Given this list of marker genes GALK2, TAF6, CHID1 (NCBI Gene Id 66005), CYSLTR1, LAIR1, SMYD4, PRC1 (protein regulator of cytokinesis 1), MBLAC2, NCOR2, LEPROTL1, UBLCP1, RDH12, PPAT, SDHA (NCBI Gene Id 6389), CD38, ZNRF2, ITGB1, ARHGAP1, SH3KBP1, PLXDC2, IRF2, PABIR2 (NCBI Gene Id 159090), RYK, UBQLN4, RNF13, SPI1, EIF4G1 (NCBI Gene Id 1981), MCM2 (NCBI Gene Id 94687), MPP1, NEDD4, DDB1, PRKAG2, LARS2, MLH1, IDS, PKN1, EHMT1, LRRC61, AIFM1, CD48, PPP1R21 (protein phosphatase 1 regulatory subunit 21), PIP4K2B, MLKL, SYT11, H2BC9, H2AC25, RACGAP1, MESD, GAS7, VPS45, HPS6, PTPRVP, NXPE3, XRN1, FGL2, TAOK3, TBCK, SEC24D, E2F6, CCDC69, PIP4P2, SLC35B4, ATP6V1C1, MDC1, HIRA, CYP20A1 (cytochrome P450 family 20 subfamily A member 1), UBQLN2, FAM168A, ACLY, SLC39A10, APBB1IP, SKAP2, ADD1, PPDPF, NFYB, BARD1, THOC5, DPCD, RPUSD3, OTUB1, DHX29, DHX32, FAM162B, INCENP, MPI, KNL1, INPP5B, TJP3, KIF20B, CHD9, SAMM50, SYNRG, BLVRA, COG7, CDC25B, ZBTB3, EPHA8, GNA15, SIAE, USP45, TBC1D7, SLC35A5, FAM111A, ATPAF1, PRMT7, THUMPD2, ZBTB8A, GBF1, PBK, SIKE1, DHX16, TXNDC16 (thioredoxin domain containing 16), MEN1, ACAT1, GLTP, THAP11, HP1BP3, SEPHS2, NUP133, POLR3K, MIGA1, NUMA1, CERS6, ASAH2, CPNE3, PCYOX1 (NCBI Gene Id 63081), CUTC (cutC copper transporter), TMTC4, XPNPEP1, NCOA7 (nuclear receptor coactivator 7), EME1, NUP155, MAP2K1, XPO6, GPATCH2, NUP210, IMPA1, CALHM6, CDIN1, PCYT1B, QDPR (quinoid dihydropteridine reductase), POC1B, COX19, HIP1, SDF2L1, UBTF, SPPL3, SEPHS1, HNRNPUL1, MTMR9, ACAP2, CHFR, CDC25C, ECSIT, FBXL14, CDK2AP1, CMTM6, PTCH1, OPA1, CENPF, BCS1L, TRAPPC1, GLIPR1L2, IPO9, GMFG, NXN, USP25, SPICE1, MSL1, CD79B, JAK1, SLC2A3, UROS, LRRC1, DBNL, AKR1B10, SLAIN2, here is a description of the gene set: IFNs are highly pleiotropic cytokines also endowed with marked anti-angiogenic activity. In this study, the mRNA expression profiles of endothelial cells (EC) exposed in vitro to IFN-alpha, IFN-beta, or IFN-gamma were determined. We found that in HUVEC as well as in other EC types genes were upregulated (>2-fold increase) by IFNs, including genes involved in the host response to RNA viruses, inflammation, and apoptosis. Interestingly, genes showed a >5-fold higher induction by IFN-alpha in EC compared to human fibroblasts; among them, the gene encoding the angiostatic chemokine CXCL11 was selectively induced by IFN-alpha in EC along with other genes associated with angiogenesis regulation, including CXCL10, TRAIL, and guanylate binding protein 1 (GBP-1). These transcriptional changes were confirmed and extended by quantitative PCR analysis and ELISA; whereas IFN-alpha and IFN-beta exerted virtually identical effects on transcriptome modulation, a differential gene regulation by type I and type II IFN emerged, especially as far as quantitative aspects were concerned. In vivo, IFN-alpha-producing tumors over-expressed murine CXCL10-11, GBP-1 and TRAIL, with evidence of CXCL11 production by tumor-associated EC. Overall, these findings improve our understanding of the anti-angiogenic effects of IFNs by showing that these cytokines trigger an anti-angiogenic transcriptional program in EC. Moreover, we suggest that quantitative differences in the magnitude of the transcriptional activation of IFNresponsive genes could form the basis for cell-specific transcriptional signatures. studied in species Homo sapiens Genes down-regulated in endothelial cells: interferon beta versus IFNG. from publication Indraccolo S, Pfeffer U, Minuzzo S, Esposito G, Roni V, Mandruzzato S, Ferrari N, Anfosso L, Dell'Eva R, Noonan DM, Chieco-Bianchi L, Albini A, Amadori A (PMID 17202376) Human Gene Set: GSE3920_IFNB_VS_IFNG_TREATED_ENDOTHELIAL_CELL_DN